The following is a description of a gene set: from publication Napolitani G, Rinaldi A, Bertoni F, Sallusto F, Lanzavecchia A (PMID 15995707) studied in species Homo sapiens Human Gene Set: GSE2706_UNSTIM_VS_8H_LPS_DC_DN Toll like receptors (TLRs) sense microbial products and initiate adaptive immune responses by activating dendritic cells (DCs). Since pathogens may contain several agonists we asked whether different TLRs may synergize in DC activation. We report that in human and mouse DC TLR3 or TLR4 potently synergize with TLR7, TLR8 or TLR9 in the induction of selected cytokine genes. Upon synergistic stimulation, IL-12, IL-23 and Delta-4 are induced at levels 50-100 fold higher than those induced by optimal concentrations of single agonists, leading to enhanced and sustained TH1 polarizing capacity. Using microarray analysis we show that only 1.5% of the transcripts induced by single TLR agonists are synergistically regulated by combinations of TLR4 and TLR8 agonists. These results identify a combinatorial code by which DCs discriminate pathogens and provide (suggest) a rationale to design adjuvants for TH1 responses. Series_overall_design: 3 untreated, 3 treated with LPS at 2h, 3 treated with LPS at 8h, 3 treated with R848 at 2h, 3 treated with R848 at 8h, 3 treated with LPS + R848 at 2h, 3 treated with LPS + R848 at 8h Genes down-regulated in comparison of unstimulated dendritic cells (DC) at 0 h versus DCs stimulated with LPS (TLR4 agonist) for 8 h., and this is the list of marker genes: NEMP1, PTP4A2, PTGIR, BCL11A, HIVEP1 (NCBI Gene Id 3096), SPAG1 (sperm associated antigen 1), DCUN1D3, GALNT3, BCL10-AS1, NAMPT, DUSP5, SIPA1L1, RNF213, LILRB2, RETREG1, UBE2Z, GCH1, IRAK2, RUBCN, RDX, TMEM254-AS1, LILRA3, KIAA0040, BAZ1A, NDP (NCBI Gene Id 4693), NCK2, STAT4, MFN1 (NCBI Gene Id 55669), TRIB1, DUSP1 (NCBI Gene Id 1843), SPTBN5 (NCBI Gene Id 51332), COBL, DDX60L, IL15, GBE1, IRF7, C15orf48 (chromosome 15 open reading frame 48), ITGB8, GPA33, CFAP65, IQCG, C3orf52, OTUD4, ICAM1, AIM2, ZBTB43, GRINA, LAMB3, TAP2, BATF, AK8, MYO10, VAV2, LGALS9, DDX60, RRAGC, EHF, TRAF3IP3, DESI1, STX17, AZIN2 (NCBI Gene Id 113451), HES4, VCAN, ABCB5, RBM43, UBXN2A, LYSMD2, IFNB1, TXN, CNKSR3, GPR137B, UAP1, HCAR3, ARAP2, EDEM1, JAK3, PIM3, IL6 (interleukin 6), ARHGEF2, LMAN1L, CALHM6, CSRNP1, PARP14, LRRC77P, DRAM1, TUBB2A, CRACD, ODR4, PLAT, TULP1 (TUB like protein 1), ZNRF1, SPAG9, BAALC, SLC25A28, PLEKHG2, TMEM268, MB21D2, IL10RA, STIMATE, PLXNC1, C1orf21, STK26, SNHG15, ATF5, AFDN, PNPT1, PML, CASP10, NBL1, STAT3, MT1M, RFTN1, EXT1, RIPK2, PCID2, SLCO5A1, SSB, NFKB1, LINC00467, ZNF341 (NCBI Gene Id 84905), TNFAIP8 (TNF alpha induced protein 8), PSME2, FEZ1, SPC25, STX11, TNFAIP2, PIWIL4, SIAH2, KCNA3 (potassium voltage-gated channel subfamily A member 3), TRAFD1, ZNF267, RTP4, ARHGAP25, GUCY1B1, MIR3945HG, ZBTB32, ZBTB17, PCGF5, ALDH1L2, SOCS3, CD200, RBCK1, LYRM1, UNC5C, C17orf58, TDH, DNAAF1, TNFAIP3, SLC38A5 (solute carrier family 38 member 5), DTX3L, BCL2, MXD1, IDO2, SERPINA12, CRISPLD2, SERPINA1, CYP27B1 (NCBI Gene Id 5135), USP53, DOT1L, CYRIA, RCN1, F2R, NMI, ADA, C1GALT1, CBLIF, PGAP1, MECP2, LAMA3, ADAM19 (ADAM metallopeptidase domain 19), CEP135, SOX11, VEZF1, USP30-AS1, EIF2AK2, IL36G, PDE4DIP, NUB1, SERPINB7, PCDH12, MT1H, SERPINB1, OPTN, ALOX15B, GBP5, TNIP1, RPS6KC1, RAB30, BNIP3, PELI1, SRSF4, EZH2 (enhancer of zeste 2 polycomb repressive complex 2 subunit), MAP4K4 (mitogen-activated protein kinase kinase kinase kinase 4), GRAMD1A, SEMA3A, FNBP1, TNFAIP6 (TNF alpha induced protein 6), RGS1